Given this list of marker genes Eps15l1, 1700030K09Rik, Slc25a42 (NCBI Gene Id 73095), Gm18066, Gm10283, Gm15355, Mir28b, Sh3rf1, Klf2, Nr2f6, Gm2961, Trim60, Rfxank, Zfp617, 2010320M18Rik, Zfp709, Tktl2, Slc5a5, Gm15354, A230052G05Rik, Iqcn, Tm6sf2, Hsh2d, Nek1, Gm3336, Gm45734, Atp13a1, Arrdc2, Jund, Pgpep1, Upf1, Potefam3c, Gm45651, Slc27a1, Gm7850, LOC665443, Anxa10, Sh2d4a, Gm43263, Crlf1, 4930470O06Rik, 1700001D01Rik, Rab8a, Gdf1, Gm25275, Zfp963, Pgls, Gm26164, Rab3a, Mir6769b, Aadat, Gm25906, Gm3365, Palld, Ssbp4, Lpl, Gm7948, Slc35e1, Zfp866, Mir710, Mir7067, Nat2, Gm45249, Ocel1, Mast3, Potefam3d, Mir7066, Gm44391, Gm7688, Gdf15, Lsm4, Msmo1, Hspd1-ps2, Hmgn2-ps, Tll1, Gm23329, Ndufa13, Gmip, Fkbp8, Crtc1, Gm34623 (predicted gene, 34623), Comp, Gm33178, Gm24236, Ccnb2-ps, Ddx49, Large1 (NCBI Gene Id 17871), Gm9755, Cyp4f18, Zfp964, Gm34730, Mir1969, Trim61, Gatad2a, Nxnl1, Ushbp1, Hpf1, Gm7432, Sin3b, Armc6 (NCBI Gene Id 76813), Myo9b, Plvap, Mir7068, Unc13a, Colgalt1, B230317F23Rik, Cpe, Gm26123, Naf1, Gm5373, Gm45756, Gm24677, Gm22324, Gm45445, Gm45650, Kcnn1, Use1, Gm7561, Npy1r, 1700020G03Rik, Ifi30, Gm5350, Ap1m1, Mfap3l, Trim75, Pik3r2, Ell, Borcs8, Gm18646, 1700026F02Rik, Sugp1, Fcho1, Rpl18a, Psd3, Yjefn3, Gm10654, Isyna1, Gm15549, Cbr4, Gm48810, Gm18924, Zfp930, Gm33103, Babam1, Tmem221, Gm23515, Gm24580, Klhl26, Gm45405, Mvb12a, Gm7619, Gm3835, Gm29705, Gm11175, Gm10033, Gm39197, Bst2, Or2z9, Gm32568, Marchf1 (membrane associated ring-CH-type finger 1), Gm35521, Nat1, Cilp2, Rps7-ps1, Uba52, Nr2c2ap, Csgalnact1, 6330537M06Rik, Cib3, Ccdc194, Ano8, Gm25052, Gm7730, Gtpbp3, Crry-ps, Gm39185, Fam32a, Gm24274 (NCBI Gene Id 115487059), Mrpl34, Cherp, Zfp882, 4930512H18Rik, Gm35572, Sgo2b (shugoshin 2B), F2rl3, Gm18860, Spock3, Tmem161a, Mau2, Pbx4, Nwd1, Zfp868, Vmn2r-ps91, Gm2975, Gm7624, Pde4c, Homer3, Niban3, Gm10015 (predicted gene 10015), Haus8, Abhd8, Apela, Insl3, Lpar2, Gm7943, Tma16, Or2z8, Tpm4, Hapln4, Gm32507, Gm18645, Mpv17l2, Npy5r, Jak3, Tssk6 (NCBI Gene Id 83984), Gm35857 (NCBI Gene Id 102639577), Gm35713, Med26, Lrrc25, B3gnt3, Tmem38a, Ncan, Cers1, Snora68, Gm22018, Gm7639, Il12rb1, Dda1, Gm15991, Clcn3, Rex1bd, Aprt-ps, Gm19170, Mir7240, Kxd1, Cope, Nat3, Zfp781a, Smim7, Gm17435, Smim31, Gm7684, Ddx60, Ankle1, Or1ab2, Gm36247 (predicted gene, 36247), Tmem59l, Slc18a1, Calr3, Gm35368, Atp6v1b2, Stambp-ps2 (NCBI Gene Id 100416243, STAM binding protein, pseudogene 2), Zfp961, 1700125H03Rik, Zfp869, Sugp2, Ccdc124, Lzts1, Gm10997, Ints10, Tmem192 (NCBI Gene Id 73067, transmembrane protein 192), Klhl2, Map1s, Mef2b, here is a description of the gene set: species: Mus musculus Mouse Gene Set: chr8B3